Given this list of marker genes Tmx1, C1qtnf1, Ccm2l, Cd24a, Prkg1, Zfp703, Sh2b3, Alox12, Ubash3b, Ceacam1, Cd9, Prkcd, Serpine2 (NCBI Gene Id 20720), Adamts18, Rdx, Map2k1, here is a description of the gene set: Mouse Gene Set: GOBP_NEGATIVE_REGULATION_OF_HOMOTYPIC_CELL_CELL_ADHESION species: Mus musculus Any process that stops, prevents, or reduces the frequency, rate, or extent of homotypic cell-cell adhesion.